Given this list of marker genes RAP1B, RAC1, RAP1A, DOCK7, RAPGEF1, HGF, CRK, GRB2, MET, GAB1, CRKL, here is a description of the gene set: Human Gene Set: REACTOME_MET_ACTIVATES_RAP1_AND_RAC1 MET activates RAP1 and RAC1 species: Homo sapiens